The following is a description of a gene set: from publication Qualls JE, Neale G, Smith AM, Koo MS, DeFreitas AA, Zhang H, Kaplan G, Watowich SS, Murray PJ (PMID 20716764) Nitric oxide (NO) produced by macrophages (MØs) is toxic to both host tissues and invading pathogens and its regulation is therefore essential to suppress host cytotoxicity. MØ arginase 1 (Arg1) inhibits NO production by competing with NO synthases for arginine, the common substrate of NO synthases and arginases. Two signal transduction pathways control Arg1 expression in MØs. First, a MyD88-dependent pathway induces Arg1 in intracellular infections, while a second Stat6-dependent pathway is required for Arg1 expression in alternativelyactivated MØs. We found that mycobacteria-infected MØs produce soluble factors that induce Arg1 in an autocrine-paracrine manner via Stat3. We identify these factors as IL-6, IL-10 and GCSF. We further establish that Arg1 expression is controlled by the MyD88-dependent production of IL-6, IL-10 and G-CSF rather than cell intrinsic MyD88 signaling to Arg1. Our data reveal the MyD88-dependent pathway of Arg1induction following BCG infection requires Stat3 activation and may result in the development of an immunosuppressive niche in granulomas due to the induced Arg1 production in surrounding uninfected MØs Genes up-regulated in macrophages 12h after M. bovis BCG infection: wildtype versus MYD88 knockout. Human Gene Set: GSE22935_WT_VS_MYD88_KO_MACROPHAGE_12H_MBOVIS_BCG_STIM_UP species: Homo sapiens, and this is the list of marker genes: FRG1, SERPINA6, MCHR1, DEPDC5, ARID5A, DCBLD1, EVI5L, MEIS2, SEC14L1, DIO2, MIS18A, BTG1, PDPN, REL, GNB1, MED18, MTAP, RBM15B, MLC1, MGAT1, NPHS2, HMOX1, UCK2, MFSD14B, CD38, RAD23B, SRSF2, WDR48, SYN1, TCERG1L, TMPRSS15, CTSC, RAB17, SH3GL3, LRRIQ3, PER1, SNX18, DPP4, NFIL3, ANTXR1, HMGA1, DRC12, NCS1, MADD, MEDAG, FBLN2, KLF13, SEZ6L2, PBX1, EHD2, LIPG, ATP2A2, SOCS3, NLGN2, WDFY1, IL6, CNPY3, NR4A1, NEDD9, POMT1, NOPCHAP1, DDIT4, ZNF189, PDLIM7, ACIN1, PPP1R15A, ST6GALNAC1, KREMEN1, LAMP1, TPST2, TCEA1, SERPINH1, C11orf97, CFL1, CD27, CDX1, CLSTN2, INTS15, TPP1, MSN, SH3RF1, HAS1, PRAF2, EMB, TPM3, CYP24A1, CLCN4, NYNRIN, SFXN5, THAP6, PODXL, SLC22A15 (solute carrier family 22 member 15), ATP1A3, S1PR1, ALDH1A2, TCTN3, TMEM252, COPG1, PSME3, ZFC3H1, RAC1, HTRA3, YWHAE, SLC38A4, DUSP5, TMEM178A, PTPN21 (NCBI Gene Id 11099), AP2A2, BRD4, CLEC16A, FN3KRP, HSP90B1, CEBPB, THBS1, ZNF418, CLDN2, HIC1, CCSER1, STEAP1, PRR13, USP17L2, VPS33B (NCBI Gene Id 55513), ELK1, ST6GALNAC2, SF3B3, HYOU1, RIPK1, RAB11FIP1, ADPGK, JUND (JunD proto-oncogene, AP-1 transcription factor subunit), GNG13, TTLL9 (NCBI Gene Id 164395), NUF2, ATP6AP1, SLC7A11, GPR151, SLC39A14, SLC6A2, SGK1, STOML3, TERF2IP, LVRN, GRB2, CXCL6, APOLD1 (apolipoprotein L domain containing 1), ADAMTS1, ATP6V0A2, PPP2CB, SHOC2, SMIM3 (NCBI Gene Id 85027), SEC31A, KMT2D, DNM3, SMIM17, MASP2, SSH2, SLC25A44, IDO2, TRPV6, LONP2, TMTC4, NAB1, CST7, ARHGAP10, CACNA2D4, CERS6, STK17B, MATCAP2, TSPAN5, PDCL2, SEC24D, SF3A1, HIF1A, NR4A2, DNAJC14, FBN1, TCF23, GGT7, TFDP1, SLC3A2 (solute carrier family 3 member 2), GSR (glutathione-disulfide reductase), NLRP3, CDK12, TDRD9, F2RL3, PIGQ, SELE, DGKQ, RSPH6A, UBE2N (NCBI Gene Id 7334), SEC16A, MPV17L (NCBI Gene Id 255027), PDE4B, CCNT1, SPSB1, WDR83OS, TMEM258, FBXL19, ANGPTL7, KLHL32